The following is a description of a gene set: Any process that modulates the rate, frequency, or extent of the aggregation, arrangement and bonding together of proteins and RNA molecules to form a cytoplasmic mRNA processing body. studied in species Mus musculus Mouse Gene Set: GOBP_REGULATION_OF_CYTOPLASMIC_MRNA_PROCESSING_BODY_ASSEMBLY, and this is the list of marker genes: Patl2, Nbdy, Cnot6, Cnot1, Cnot6l, Pan3, Cnot2, Pan2